Given this list of marker genes RN7SKP35, C5orf34, LGR4, HES5, RARB (retinoic acid receptor beta), CLVS1, FBLN7, GLYATL2, DUT-AS1, PCYT1B, ADORA2B, TMTC4, APCDD1L-DT, RPS27P25, RNF180, LINC00113, CNTLN, PRSS56, NPVF, GATB, NOTCH1, LINC01994, RTKN2, FAM184B, CASC17, VSTM2B, TOX3, LINC01508, ARHGEF26-AS1, RPL30P14, MYBL1, DDHD1, C14orf39, MIR3659HG, CECR3, KLHL8, UQCRHL, ARHGEF26, GRB10, SORCS1, NALCN-AS1, FOXN4, NR2E1, LHCGR, OPTC, POT1-AS1, LINC01697, RFC3, PWWP3A, MOB3B, ZHX2, AOC2, CRB1, TNS1-AS1, ADARB1, ILDR2, RNU2-47P, OSTM1-AS1, LINC01387, EPHB2, LINC01621, DAPL1, GABRG3, PKD2, ABHD12B, here is a description of the gene set: Marker genes curated from the annotated cluster as represented in the Descartes Human Gene Expression During Development database. from publication Cao J, O'Day DR, Pliner HA, Kingsley PD, Deng M, Daza RM, Zager MA, Aldinger KA, Blecher-Gonen R, Zhang F, Spielmann M, Palis J, Doherty D, Steemers FJ, Glass IA, Trapnell C, Shendure J (PMID 33184181) Human Gene Set: DESCARTES_MAIN_FETAL_RETINAL_PROGENITORS_AND_MULLER_GLIA species: Homo sapiens The gene expression program underlying the specification of human cell types is of fundamental interest. The study authors generated human cell atlases of gene expression and chromatin accessibility in fetal tissues. For gene expression, the study authors applied three-level combinatorial indexing to >110 samples representing 15 organs, ultimately profiling ~4 million single cells. The study authors leveraged the literature and other atlases to identify and annotate hundreds of cell types and subtypes, both within and across tissues. Our analyses focused on organ-specific specializations of broadly distributed cell types (such as blood, endothelial, and epithelial), sites of fetal erythropoiesis (which notably included the adrenal gland), and integration with mouse developmental atlases (such as conserved specification of blood cells). These data represent a rich resource for the exploration of in vivo human gene expression in diverse tissues and cell types.